Given this list of marker genes ACTA1, IGF2, CHRNG (cholinergic receptor nicotinic gamma subunit), PPFIA4, CHRNB1, TNNT2, KIF5C, DMPK, GADD45G, ATOSB, AGPAT5, MYOD1, KLF5, HSPB8, LRP4, PRKAR2B, LGALS4, HES6, RHOB, TFRC, TNNI2, TMCC3, KLHL5, GPC1, ATP1A1, DCAKD, CDKN1A, PBXIP1, MYL4, MYBPH, HRC, SLF2, KLHDC10, PSMC3, VKORC1, PLEKHO1, DBN1, PRND, FZD3, FAM241A, FCER1G, MYOG, RUNX1 (NCBI Gene Id 861), LMNB2, AKT2, IGFBP5, GYS1, HIP1, ENO3, ATP2A1, AGO2, PDLIM3, TNNT3, CHRNA1, MYL11, CLUH, VASH2, BCL6, ANXA11, HS2ST1, ANKS1B, SVBP, MYL1, STAM, TNNC2, RB1, CPSF6, CPEB3 (NCBI Gene Id 22849), HDAC11, KIFC3, STK17B, DYSF (dysferlin), SH2B1, CFL2, CD82, CCND3, CELF1, NAV2, CKM, MYH3, HMGCS2, CACNA2D1, PACS2, BIN1 (NCBI Gene Id 274), PRSS23, SCRIB, here is a description of the gene set: from publication de la Serna IL, Ohkawa Y, Berkes CA, Bergstrom DA, Dacwag CS, Tapscott SJ, Imbalzano AN (PMID 15870273) Genes up-regulated in NIH 3T3 cells (fibroblasts) 24 h after inducing MyoD differentiation program. studied in species Mus musculus Human Gene Set: DELASERNA_MYOD_TARGETS_UP The activation of muscle-specific gene expression requires the coordinated action of muscle regulatory proteins and chromatin-remodeling enzymes. Microarray analysis performed in the presence or absence of a dominant-negative BRG1 ATPase demonstrated that approximately one-third of MyoD-induced genes were highly dependent on SWI/SNF enzymes. To understand the mechanism of activation, we performed chromatin immunoprecipitations analyzing the myogenin promoter. We found that H4 hyperacetylation preceded Brg1 binding in a MyoD-dependent manner but that MyoD binding occurred subsequent to H4 modification and Brg1 interaction. In the absence of functional SWI/SNF enzymes, muscle regulatory proteins did not bind to the myogenin promoter, thereby providing evidence for SWI/SNF-dependent activator binding. We observed that the homeodomain factor Pbx1, which cooperates with MyoD to stimulate myogenin expression, is constitutively bound to the myogenin promoter in a SWI/SNF-independent manner, suggesting a two-step mechanism in which MyoD initially interacts indirectly with the myogenin promoter and attracts chromatin-remodeling enzymes, which then facilitate direct binding by MyoD and other regulatory proteins.